The following is a description of a gene set: Human Gene Set: GOBP_CITRULLINE_BIOSYNTHETIC_PROCESS studied in species Homo sapiens The chemical reactions and pathways resulting in the formation of citrulline, N5-carbamoyl-L-ornithine, an alpha amino acid not found in proteins., and this is the list of marker genes: CAD, OTC, ATP2B4, ALDH18A1, CPS1